Given this list of marker genes VPS35L, ABCC5, C5AR1, ULK2, LARP4B, FCGR2B, ALG13, TRMT61B, RASA1, TMEM160, ZNF83, RASAL1, IL33, SNX5, FCGR2C, IFT74, MBNL3, IRS1, DAP3, EDEM3, ZNF549, E2F8 (NCBI Gene Id 79733), NAXD, UFSP2, PPM1A, TXNDC15, TTC38, SNU13, SEPHS2, ARMC1, GPALPP1, RPS12, MAP3K7, STAMBPL1, POFUT2, C1orf50, DENND5B (NCBI Gene Id 160518), CNBP, MARK3, NECTIN3, MARCHF5 (NCBI Gene Id 54708), RRP8, H2AJ, CRYZL1, ADH5, RFX7, PTGES3, ARL3, TSNAX, ZNF362, FUCA1, VTI1B, PPFIA1, CD163, SOD1, YIPF1, TRIM14, SLC25A6, PHTF1, SNX24, SELENOP, AZIN1, SV2B, SHCBP1 (NCBI Gene Id 79801), PRG4, FAF2, PRUNE2, CCDC170, ACYP2, BAG4, DSTN, SSBP1, STX12, RTF1, STAB1, P2RY14, LRIG2, U2AF2 (NCBI Gene Id 11338), TACC1, GALC, MAP4K5, CRISP2 (NCBI Gene Id 7180), HOOK1, SPART, LZTFL1, PRKAA1, BIN3, FCGR1A, RAD51AP1, DMXL2, ABAT, SAR1A, CMKLR1, AHCTF1, WNT5B, PIBF1, SPTSSA, GPR137B, MSRB2, UGT2B15, DTWD1, MKNK1, ZNF268, GMPR2, ARFGEF1, USP39, INTS12, PMF1, TXLNG, OXSR1, MIA2, CLDN8, HRH1, FLI1, RTL8A, NME7, PARL, KCTD3, FCGR3B, SLC36A1, SRPK2, COX7A2L, ANKRA2, KLHL23, UNC13A, LRP2BP, SYNE1, MAGEA8, ATP8B4, ECPAS, CEP290, SELP, P2RY13, CRH, DICER1, CITED2, FYCO1, GOLPH3, NCF4, SRP54, CD14, MOB1A, USO1, RPS6KB1, IFT20, CUL4A, STX2, DYSF, IL2, CIRBP, DCUN1D4, GTF3C3, N4BP3, LIG4, RARRES1, PHF20, IRAG2, PCDH1, STX7, PPP2R3C, MEAK7, LAMTOR3, RCBTB2, WASHC4, ZNF500, RARS2, OLFM4, ZNF529, ACTR6, RAG1, AGGF1, GAB2, AGTPBP1, PLXNC1, TSR2, WIF1, NISCH, MARCHF6, C1orf216, MRPL9, PIGN (phosphatidylinositol glycan anchor biosynthesis class N), KAT6B, HMGB2, P2RY1, ASF1A, KLHL24, UBE2V2, TBC1D15, ACTR10, TPD52L2, AQR, FAM13B, RACGAP1, ZNF226, TMEM35A, NBR1, SRSF5, SSBP2, ZNF84, CBR3, here is a description of the gene set: Human Gene Set: GSE18281_CORTICAL_THYMOCYTE_VS_WHOLE_CORTEX_THYMUS_DN Interaction of hematopoietic progenitors with the thymic stromal microenvironment induces them to proliferate, adopt the T cell fate, and asymmetrically diverge into multiple T lineages. Progenitors at various developmental stages are stratified among different regions of the thymus, implying that the corresponding microenvironments differ from one another, and provide unique sets of signals to progenitors migrating between them. The nature of these differences remains undefined. Here we use novel physical and computational approaches to characterize these stromal subregions, distinguishing gene expression in microdissected tissues from that of their lymphoid constituents. Using this approach, we comprehensively map gene expression in functionally distinct stromal microenvironments, and identify clusters of genes that define each region. Quite unexpectedly, we find that the central cortex lacks distinctive features of its own, and instead appears to function by sequestering unique microenvironments found at the cortical extremities, and modulating the relative proximity of progenitors moving between them. species: Homo sapiens from publication Griffith AV, Fallahi M, Nakase H, Gosink M, Young B, Petrie HT (PMID 20064453) Genes down-regulated in cortical thymocytes versus thymus whole cortex.